Given this list of marker genes LHX6, DRD2, CNTN2, SLIT3, ARL13B, ARX, SLIT2, FEZF2, SLIT1, NRG3, RAC1, DRD1, here is a description of the gene set: species: Homo sapiens Human Gene Set: GOBP_SUBSTRATE_INDEPENDENT_TELENCEPHALIC_TANGENTIAL_MIGRATION The process where neuronal precursors migrate tangentially in the telencephalon, primarily guided by interactions that do not require cell-cell contact.